Given this list of marker genes IQGAP2, BICRAL, IPO9, KCTD9, IBTK, ABCE1, INO80C, VDAC3, SELL, ERH, PRPF3, POGK, ACOD1, SRGAP3, HAT1, RBBP6, EPS8, HNRNPUL1, MSN, RAN, ITGA2, HSD17B12, NT5E, MFSD14B, BMPR2, MCM6, SPAST, SNAP29, SDHA, DNMT1, SSH1, VDAC1, IL2RA (interleukin 2 receptor subunit alpha), PKNOX1, RPS6KA5, SAMD3, PSAT1, PRC1, CHAF1B, XDH, H4C9, GMCL1, MAP3K5, REEP5, HMGCR, SLC16A1, KIF4A, CBLN2, MAGI3, IMMT, NEBL, CDC27, LPCAT1, MELK, CEMIP2, NIN, MAN2A1, H2AC15, TNFSF9, NUP205, PRR5L, FLII, KIF2C, ARL5A, SSRP1, MEAF6, KIF1B, CPNE3, RAB18, PBRM1, SMURF1, CDC25A, FBXO22, CNTRL, LANCL2, TTC3, DCAF1, PSMD1, MCM2, CHST2, TLR4, CNTLN (centlein), BPNT1, SMPDL3B, DGCR8, ARAP2, DTL, PIK3C2B, H2BC9, TACC3, COPB2, RNF168, SPTLC2, AKT2, SEPHS1, PAPOLA (NCBI Gene Id 84718), SEPTIN11, CRIP2, GSPT1, BBS9, PTPN11, PHF20L1, SORD, MPHOSPH9, RNASE9, CLTC, DLGAP5, ANAPC2, CYFIP2, ITGB2 (integrin subunit beta 2), RFWD3, DENND5A, MCM3, EFHD2, LRRK1, HSP90AB1, GINS3, WDR35, CNEP1R1, FMR1, MIR216B, FAR1, GPR33, NUP107, ESYT1, HMGN2, GPSM2, SF3B2, CYP8B1, G3BP1, CCNE1, TRIOBP (TRIO and F-actin binding protein), CORO1C, H2BP2, TRPM6, IL18RAP, MAD2L1, MSH4, CLPB, NFYB, YWHAE, LRP6, GALNT7, TRIM37, FAM20B, CX3CR1, CBX5, EXOC3, YWHAB, NEK2, NUF2, CDCA7, ZRANB1, ITIH5, NECAB3, HSPD1, NCAPG2, UHMK1, NSD2, IDI1, TOP2A, RCBTB1 (NCBI Gene Id 55213), ENTPD1, ATP2A2, FIG4, here is a description of the gene set: Genes down-regulated in IL10 knockout macrophages stimulated by IL10 versus NFKB1 knockout macrophages stimulated by IL10 and LPS. from publication Yang HT, Wang Y, Zhao X, Demissie E, Papoutsopoulou S, Mambole A, O'Garra A, Tomczak MF, Erdman SE, Fox JG, Ley SC, Horwitz BH (PMID 21217011) Human Gene Set: GSE19941_IL10_KO_VS_IL10_KO_AND_NFKBP50_KO_LPS_AND_IL10_STIM_MACROPHAGE_DN studied in species Homo sapiens Bone marrow-derived macrophages were produced from mice lacking IL-10 alone (IL10-def) or mice lacking both IL-10 and the p50/p105 subunit of NF-kB (p50/IL10), and left unstimulated, stimulated with LPS (1 ng/ml) or stimulated with LPS and IL-10 (0.3 ng/ml).